The following is a description of a gene set: Apraxia A defect in the understanding of complex motor commands and in the execution of certain learned movements, i.e., deficits in the cognitive components of learned movements. Human Gene Set: HP_APRAXIA studied in species Homo sapiens, and this is the list of marker genes: MRE11, TNR, INPP5E, DLAT, TCTN2, DDOST, B9D1, AFG3L2, NKX2-1, STIL, CACNA1A, ARMC9, CHCHD10, YME1L1, KCNJ11, COG8, ARPC4, PIGO, CEP104, IFT74, PIGY, INS, TMEM67 (transmembrane protein 67), CDON, CHD3, CHMP2B, ADGRG1, PGAP2, ATP1A2, XRCC4, FOXG1, PNPT1, KDM6B, NPHP1, APP, PIBF1, SNX14, ARL13B, KANSL1, FOXP2, FA2H, MED13, DLL1, PURA, DISP1, TMEM107, SPG21, SMPD1, PLCH1, MECP2, TOMM40, AHI1, ATP6AP2, KIAA0753 (NCBI Gene Id 9851), RPGRIP1L, TBK1, VCP, TMEM216, SALL4, TCTN1, NTNG1, CRKL, TUBB2B, PGAP3, EPM2A, TYROBP, TRAPPC11, B9D2, CACNA1G, C9orf72, SORL1, SLC25A15, MAST1, ABCC8, PTEN, MAPT, TMEM106B, ARL3, EXOSC3, GBA1, PIGL, TCTN3, KIAA0586, UBE3A, PDX1, FRRS1L, PLA2G6, RAI1, SLC1A3, GAS1, DNM1L, PMPCA, PEX2, TMEM138, NPTX1, SPR, PSEN2, PSEN1, KATNIP, FOXH1, CBY1, TGIF1, PEX10, PIK3R5, SETX, NODAL, SQSTM1, TOE1, XRCC1, STAG2, KDM1A, NGLY1, LAMA1, BCR, DMPK, CDKL5, SHH, SRCAP, SUFU, PACS1, ZIC2, SH2B1, PANK2, HTRA1, TTC19, PNKP, APTX, APOE, CSPP1, PEX6, ABCD1, CHD1, CWF19L1, CRIPTO, TOGARAM1, RORA, UFC1, TMEM231, OFD1, KCNH1, IFT172, FGF8, GPAA1, SOX3 (SRY-box transcription factor 3), ATP13A2, TIMM8A, TUBA1A, BLTP1, USP7, PTCH1, TPP1, SYNJ1, FOXP1, GRIN2A, SMC1A, H4C11, PIGW, STUB1, FUS, CSF1R, PLP1, NUP54, PI4KA, GALT, SPART, PRNP, TAF4, TUBB3, GRN, ZC4H2, MYO9A, TMEM237, CEP290, GLI2, GRID2, RNF135, ATXN2 (NCBI Gene Id 8095), PRKAR1B (NCBI Gene Id 645590), SLC2A1, EBF3, GCK, GABBR2, ATP1A3, MYT1L, SLC6A8, PIGV, MAPK1, TBP (TATA-box binding protein), TREX1, PDE6D, CHN1, CEP41, STAT3, BRAF, TREM2, HMBS, CLTC, TMEM218, POU4F1, GALK1, HECTD4, NONO, TUBB4A, VPS11, ABCA7, CC2D2A, AARS2 (alanyl-tRNA synthetase 2, mitochondrial), HYLS1, SIX3, SLC30A9 (solute carrier family 30 member 9), MKS1, CEP120, FGFR1, SRPX2, TARDBP, CPLANE1, MAFB, ITPR1